Given this list of marker genes C1R, C1S, C1QB, C1QA, ENSG00000275063, C1QC (complement C1q C chain), here is a description of the gene set: SARS-CoV-2 S to classical pathway of complement cascade. Pathway ID: N01314. Pathway type: Pathogen. Pathway class: nt06513 Complement cascade. Human Gene Set: KEGG_MEDICUS_PATHOGEN_SARS_COV_2_S_TO_CLASSICAL_PATHWAY_OF_COMPLEMENT_CASCADE species: Homo sapiens Pathway Definition from KEGG: S -> (IgG,IgM) -> ((C1QA,C1QB,C1QC)+C1R+C1S))